Given this list of marker genes CHRNA3, CHRNB2, LYNX1, PATE4, TMEM35A, CHRNA7, SPDYE11, CHRNA4, LY6G6D, CDK5, PATE1, LY6S, CHRM4, LYPD1, CHRNA1, CHRM3, CHRNB1, CHRNA2, CHRNA6, APP, LYPD6B, CHRM5, CHRM2, CHRNB3, CHRNE, LY6E, ANXA9 (annexin A9), CHRNB4, LY6H, LYPD6, SLURP1, CHRND, CHRM1, PSCA, CHRNA5, CHRNG (cholinergic receptor nicotinic gamma subunit), SLURP2, here is a description of the gene set: Combining with an acetylcholine receptor ligand and transmitting the signal from one side of the membrane to the other to initiate a change in cell activity. Human Gene Set: GOMF_ACETYLCHOLINE_RECEPTOR_ACTIVITY studied in species Homo sapiens